Given this list of marker genes TCEAL4, EMP2, IGFBP5, COL1A1, SOD3, ITGB1, FGF7, FBLN1, TMEM98, SDC2, MFGE8, GNG11, MEG3, SNHG32, PKIG, PEG10, RNASE4, COL6A3, AEBP1, SOX4, PLPP3, SMOC2, PPP1R14A, CALD1, C7, SGCE, CMYA5, CYB5A, FILIP1L, LTBP4, NBL1, ADAMTS5, DSTN, EPHX1, MMP23B, NDRG2, MIR99AHG, IFITM3, MMP2, TNS1, SERPINE2 (serpin family E member 2), NDN, MATN2, MAP1B, TPM1, LGALS1, COL6A2, DDR2, ST13, SERPING1, OSR2, SLC7A2, CCN5, APOD (apolipoprotein D), CLDN11, BGN, LUM, ABLIM1, PRELP, LRRC17, GPX3, CDH11, ACSM3, IGFBP2, CD59, BEX3, DCN, C11orf96, IMPDH2, NR2F2, ACTA2, CXCL12, TCF21, SULF2, OLFML3, PDGFRA, MARCKSL1, STAR, APOE (apolipoprotein E), FHL2, SPRR2F, TCEAL1, EMILIN1, GSTM3, NFIC, CSRP1, TCEAL9, CAVIN1, MYLK, CAV1, MGP, CDKN1C, PEG3, CTSK, EPB41L4A-AS1, FBN1, HTRA1, PRSS23, ADIRF, ALDH7A1, RARRES2, ABCA8, PDGFRB, CAVIN3, CALM2, HTRA3, MXRA8, COL12A1, KRT19, CAV2, LGALS3BP, SERPINF1, FOXL2, LMNA, MDK, TPM2 (tropomyosin 2), SCD5, ISYNA1, SELENOW, KANK2, TAGLN, NUPR1, ARX, TSHZ2, SELENOP, COL14A1, FRZB, CTSF, CD151, OGN, RBP1, C1R, ISLR, COL6A1, CFH, MFAP4, FXYD1, GREB1, CLSTN2, RHOBTB3 (Rho related BTB domain containing 3), PLTP, CCDC80, SPARCL1, OBSL1 (obscurin like cytoskeletal adaptor 1), IGFBP7, SVIL, MYL9 (NCBI Gene Id 10398), C1S, IGFBP4, SLC40A1, RAMP2, NR2F1, NFIB, PALLD, KLHDC8A, BNC2, here is a description of the gene set: from publication Jones ASK, Hannum DF, Machlin JH, Tan A, Ma Q, Ulrich ND, Shen YC, Ciarelli M, Padmanabhan V, Marsh EE, Hammoud S, Li JZ, Shikanov A (PMID 38578993) Human Gene Set: JONES_OVARY_STROMAL The reproductive and endocrine functions of the ovary involve spatially defined interactions among specialized cell populations. Despite the ovary's importance in fertility and endocrine health, functional attributes of ovarian cells are largely uncharacterized. Here, we profiled >genes in 257 regions from the ovaries of two premenopausal donors to examine the functional units in the ovary. We also generated single-cell RNA sequencing data for 21,198 cells from three additional donors and identified four major cell types and four immune cell subtypes. Custom selection of sampling areas revealed distinct gene activities for oocytes, theca, and granulosa cells. These data contributed panels of oocyte-, theca-, and granulosa-specific genes, thus expanding the knowledge of molecular programs driving follicle development. Serial samples around oocytes and across the cortex and medulla uncovered previously unappreciated variation of hormone and extracellular matrix remodeling activities. This combined spatial and single-cell atlas serves as a resource for future studies of rare cells and pathological states in the ovary. studied in species Homo sapiens Marker genes selected by filtering the centroid data for genes with a value > 0 for the given cell type